The following is a description of a gene set: from publication El Kasmi KC, Holst J, Coffre M, Mielke L, de Pauw A, Lhocine N, Smith AM, Rutschman R, Kaushal D, Shen Y, Suda T, Donnelly RP, Myers MG Jr, Alexander W, Vignali DA, Watowich SS, Ernst M, Hilton DJ, Murray PJ (PMID 17114459) Genes up-regulated in bone marrow-derived macrophages with IL6 knockout and 45 min of stimulation by AIL10 and LPS versus IL6 and LPS. studied in species Homo sapiens IL-10 or IL-6 stimulation of control 129xC57BL/6 murine bone marrow derived macrophages in the presence of LPS. We used microarrays to detail the global programme of gene expression changes in response to IL-6 or IL-10 stimulation in the presence of lipopolysaccharide. BMDMs were isolated from control, IL-6-/-, and IL-10-/- mice on a 129XBL/6 mixed background mice and differentiated in the presence of CSF-1 for 6-7 days. Cells were scraped and plated in 6 well plates at 2x10e6/well. Cells were washed with complete DMEM and rested for 1-2 hr before stimulation with combinations of IL-10 (10 ng/ml), IL-6 (2 ng/ml) or LPS (100 ng/ml) for 45 min or 180 mins. Complete biological replicates were performed. Human Gene Set: GSE5589_LPS_AND_IL10_VS_LPS_AND_IL6_STIM_IL6_KO_MACROPHAGE_45MIN_UP, and this is the list of marker genes: RNASEL, NCR1, IER5, RNF31, IFIT1B, DBNL, PKP3, B3GNT2 (UDP-GlcNAc:betaGal beta-1,3-N-acetylglucosaminyltransferase 2), NCAPG2, CCND1, CMTR1, MS4A6A, PHYH (NCBI Gene Id 8024), SAP30, RBPJ, PTTG1, MBD2, CTNND2, SLFN12, PSME4, SUV39H1, TLR3, LAPTM4A, AGRN, CLEC7A, HPN, AHSA1, MRPL27, GCH1, TRAK2, FRMD4A, PTPRO, PSMB10, PNP, ZCCHC2, DPYSL2, RBM43, HSH2D (hematopoietic SH2 domain containing), PDE7B, PRR5L, FYB1, GSDMD, FAT3, SLAMF9, PSEN1, NLRC5, VCAN, MMP13, MTHFR, UBA7, SLCO3A1, TREX1, IL15, RNF14, CFP, TNFSF10 (TNF superfamily member 10), LAIR1 (leukocyte associated immunoglobulin like receptor 1), GPSM2, CNP, RABIF, SAMHD1, CFLAR, DTX3L, CD300LD, CCL5, CASP4 (caspase 4), PSMB9, CCL2, XDH, SCARF1, MCEMP1, GAS7, PHLPP1 (NCBI Gene Id 23239), CASP12, GLRX, CRISP2, DENND1B, PTPN6, CCL13, MYH10, MARCHF5, ARID5A, GBP7, TLR7, PLBD1, ZUP1, CXCL10, IFI35, C1QA, RIGI, NFATC2, SELENOM, PARP14, ISG20, FGL2, MSR1, CCR5, PRPF38A, NFXL1, FCGR1A, MYCBP2, ZC3HAV1 (NCBI Gene Id 79678), HLA-B, CHMP4B, HLA-G, PARP12, TOR3A, DOCK2, ADAM8, RNF34, ADAM19, ZBP1, NAA25, BRCC3, GBP6, ZNFX1, CD200R1, IFI27L2, DDX60, LYN, AFTPH, STAMBPL1, NMI, MLKL, FCGR2B, IL15RA, GPR65, P4HA1, CXCL16 (NCBI Gene Id 58191), IL21R, CRACDL, PML, CD300LF, CD160, XRN1, NT5C3A, SLFN12L, OAS1 (2'-5'-oligoadenylate synthetase 1), NOSIP, PGK1 (phosphoglycerate kinase 1), IL12B, CD72, RSAD2, EVI2B, DCK, CD86, ADAMTS6, NKG7, TRAFD1, SAMD9L, LARP1, USB1, CDKN1A, NECTIN4, IST1, PIK3AP1, TRIM26, CCL7, CASP1, RAP2C, RNASET2, SHISA5, NCOA7, IRF9, GPR35, RCBTB2, TAP1, TMEM163, ATF7IP, CTSC, IRF4, LAMP2, PARP9, GOT2, AZI2, PLEKHA8, AIDA, MTCP1, IFITM3, HLA-DQA1, CD83, SNX2, ISG15, UBE2L6, EPSTI1, RETREG1, APOC2, AIF1, S1PR2, THEMIS2, RAB19, C1orf54, ANAPC5, TMEM184B, SDC4, ATP8B4, OAS2, MOV10, LPXN, OAS3